Given this list of marker genes NEMF, KCNK6, CCDC34, GTF3C5, CENPW, NAA40, ACTR1B, TOMM40, RARS1, MERTK, CDKL2, NUP205, SERBP1, PLPP6, LIMS4, ZNF324B, CDR2 (cerebellar degeneration related protein 2, NCBI Gene Id 1039), SH3BGRL2, SETDB1, NLRX1 (NCBI Gene Id 79671), MEF2B, ATXN10, EPB41, CEP152, WDR18, DNM1L, KIF20B, VCPKMT, NOP14, VPS45, AGPAT5, NRDC, L2HGDH, NIPA2, SRBD1, RCC1, WRAP53, PGPEP1, CA8, BRIP1, SLAMF1, SFMBT1, NCBP1, HJURP, CORO1C, TMEM38B, EXOSC7, EIF3C, ASTE1, HPSE, QNG1, PSPH, TCEANC, ZFP91, SUPT16H, RUVBL2, PHF10, FAM83D, CSTF3, NR2C2, SKA3, ARHGAP19, PTK2, MRE11, TUBD1, MOB1B, SNHG32, STARD9, MGME1, PARM1, ASPM, LSM14A (LSM14A mRNA processing body assembly factor), OSBPL3, ARFIP2, FADS2, GYG1, DNAJC2, NELFE, ITGB2, CNST, RAB5A, ELOF1, AGPAT3, ZFAND4, ERI2, FIRRM, TRMT13 (NCBI Gene Id 54618), NMT1, ATXN7L1, SMDT1, RNASEH1, SMPD4, MCPH1, APIP, MTSS1, RHOG, EYA1, TOE1, WDR90, HCCS, CACNA1H, PHF6, VCP, FMNL2, HMGA2, PLXNB2, CYP11A1, RPLP0, TWF1, BBS12, SPMIP4, TUBGCP2, DEK, ZC3H15, PUS7, TLCD3A, SNRPA1, PUS10, PEX19, RASAL1, CREG1, SLC2A4RG, HIBCH, ING2, SLC25A46, DRAM1, EXOSC2 (NCBI Gene Id 23404), GMDS, ORC6, CCHCR1, LBR, POC1A (NCBI Gene Id 25886), CDK4, VDAC1, DZIP3, PSMB2 (NCBI Gene Id 5690), AK2, IDH1, TICRR, YARS1, RBM28, PLK1, STRAP, SLC15A2, SGO2, ZNF518B, NCAPD2, SLC36A4, MAPRE1, FARP2 (NCBI Gene Id 9855), CBFB, MEST, USP37, DNAJC9, PMS2 (PMS1 homolog 2, mismatch repair system component), UBE2N, RBM44, SMARCA5, DYNC2I2, LCMT1, DDX19B, ARPC1A, PTBP3, DDIAS, SSBP4, XRCC6 (X-ray repair cross complementing 6), FAM76B, RBKS, CUL4B, USP1, ATP5F1A, CIBAR1, MIX23, RCCD1, KIAA0753, CFAP20, NDUFA8, LGALS1, CCDC122, SFTPD, HAUS7, USP2, BCL2L14, ELL2, HIPK3, AACS, BRMS1L, PKP4, MRS2, RNF4, RBMXL1, TMPO, IDI1 (isopentenyl-diphosphate delta isomerase 1), GRHL1, CCP110, GOT2, SLC22A15 (NCBI Gene Id 55356), CIT, UTP4, DDX21, here is a description of the gene set: studied in species Homo sapiens Human Gene Set: GSE5542_IFNG_VS_IFNA_TREATED_EPITHELIAL_CELLS_6H_UP Genes up-regulated in epithelial cells (6h): IFNG versus interferon alpha. Type I and type II interferons (IFNs) bind to different cell surface receptors but activate overlapping signal transduction pathways. We examined the effects of a type I IFN (IFN-acon1) and a type II iFN (IFN-g1b) on gene experession in A549 cells and demonstrate that there is a common set of genes modulated by both IFNs as well as a set of gene specifically regulated by each, reflecting the activation of different signaling pathways. In particualr, IFN-g induced many more genes of the signaling pathways, apoptosis, and cytokine interactions than did IFN-a. Even with genes induced by both IFNs there were distinctive quantitativive differences in expression. IFN-g1b plays a major role in the induction and regulation of the complement pathway. Previous work has shown a synergistic antivral and antiproliferative effect of type I and type II IFNs in cell culture and in the treament of tumors in mice. We demonstrate that a majority of genes showed and additive effect of IFN-acon1 and IFN-g1b, but a subset of gene is synergistically induced; these incluce ISG10, MX2, OAS2, and other genes known to be involved in the antiviral response, TRAIL (TNFSF10) and caspases involved in apoptosis and chemokine genes RANTES, CXCL10, and CXCL11. Greater than additive transcription of some of these genes in the presence of both IFNs was confirmed by real-time kinetic RT-PCR. Elevated induction of many of these genes may be sufficient to explain the synergistic antiviral and antitumor effects of this combination of IFNS in vivo. from publication Sanda C, Weitzel P, Tsukahara T, Schaley J, Edenberg HJ, Stephens MA, McClintick JN, Blatt LM, Li L, Brodsky L, Taylor MW (PMID 16800785)